The following is a description of a gene set: Human Gene Set: GSE37563_WT_VS_CTLA4_KO_CD4_TCELL_D4_POST_IMMUNIZATION_UP species: Homo sapiens Genes up-regulated in CD4 cells after immunization: wildtype versus CTLA4 knockout. from publication Corse E, Allison JP (PMID 22753941) CTLA-4 is thought to inhibit effector T cells both intrinsically, by competing with CD28 for B7 ligands, and extrinsically, through the action of regulatory T cells. We studied in vivo responses of normal and CTLA-4-deficient antigen-specific murine effector CD4+ T cells. In order to do these studies in a physiological model of immunity to foreign antigen, we transferred small numbers of congenically marked RAG2-deficient 5C.C7 T cells with either a normal or knockout allele of CTLA-4 into normal syngeneic B10.A recipient mice. The T cells were then activated by immunization with MCC peptide and LPS. To look for transcriptional signatures of negative regulation of T cell responses by CTLA-4, we used microarray analysis to compare transcripts in wild type and CTLA-4 KO 5C.C7 T cells four days after immunization. This is the first instance in which differences are observed in extent of accumulation of wild type and CTLA-4 KO 5C.C7 T cells., and this is the list of marker genes: DUSP13B, FSHB, CDK20, APAF1, WIPI2, ASB11, CTSO, ZDHHC17, RASA3, NEK9, HPS5, LPAR3, YPEL3, SLC12A6 (NCBI Gene Id 9990), RIF1, PKIA, XIAP, SLC6A16, RPS9, MIER1 (NCBI Gene Id 57708), SDSL, MROH1, RNF167, POU4F1, CTSD (cathepsin D), SERINC5, DNAJB4, PNPLA1, LUC7L3, OSBPL8, LMBRD1, ACTN1, ABCD2, CLINT1, RBM4B, CHST10, PPCS, PATJ, IRF1, DYNC1LI2, RHOBTB3, FGD3, CYTL1, GRAP2, TCP11L2, CEP95, CYP24A1, MEI1, CFI, ADAM17, PDPN, POMGNT1, ABCG2, GALNT18, CRHR2, MIR451A, LAPTM4B, KIF1B, CDC73, HDHD5, GALNTL5, LGALS8, FBXO16, HNF1B, SULT1E1, PPP6R3, KHNYN, EFR3A, PAPLN, FAM120C, PARG, AHCYL1, TJP3, RCBTB1, EXD1, AKT2, PDGFD, HSD17B2, SNRNP48, AK9, CNKSR2, ANO1, FGF8, TENT5C, ARPP21, LCE1E, KLHL6, CXCR1, RANBP6, SHPRH, MDP1, AKAP8L, RAPGEF6, MIR138-2, LRRC30, WDR11, OXT, CLEC18A, BTN2A2, JUP, NXPE3, ATM, TMTC4, CD163L1, EPC1, PLD1, GMCL1, NCKAP1L, LAX1, KAT6A, OSBPL2, MLLT3, DKK2, PARP14, DRC12, NRK, FAHD2A, SGK3, CEP97, DDX17, AVL9, FAM174B, STX17, SCP2, LCN10, PBX1, IREB2, ERC2, SLC25A5, ARF5, ZFTRAF1, HLTF, CDC37L1, SLC9A6, PRKD2, ASTN1, NFXL1, ARHGAP15, SPIN1, TOM1L2, HOXB2, WDR5B, FBXL7, PCMTD1, SMURF1, TSC22D3, PPP1R3C, DGKD, HELZ2, ZNF729, B3GNT7, BHLHE22, SETX (NCBI Gene Id 85506), ATE1, HCN3, LPCAT1, MPP3, REV3L, PNPLA7, PPM1K, ARL5C, VPS13C, DDX5, PXT1, CDH19